Given this list of marker genes Hdac3, Cbx5, Gatad2a, Mbd3, Tet1, Nrip1, Morf4l1, Brms1l, Znhit1, Ruvbl2, Ing3, Rbbp4, Cdk2ap2, Ncor2, Hdac7, Tbl1x, Chd5, Mideas, Hdac8, Ruvbl1, Dnttip1, Setd5, Kat5 (K(lysine) acetyltransferase 5), Zfp541, Rcor1, Anp32e, Sinhcaf, Hint1, Trerf1, Kdm3b, Hdac10, Mta1, Brd8, Arid4a, Mbd2, Rere, Kdm3a, Zfp217, Hdac5, Rcor2, Phf12, Trrap, Sap30, Brms1, Arid4b, Dmap1, Rcor3, Mecom, Ncor1, Srcap, Hdac2, Suds3, Phf21a, Ep400, Mta2, Csnk2a1, Hdac6, Gatad2b, Ogt, Tbl1xr1, Ing2, Sall1, Jmjd1c (NCBI Gene Id 71364), Sap18, Hdac1, Actr6, Hdac11, Sin3b, Hdac9, Sap130, Sin3a, Hr, Chd4, Satb2, Hdac4, Ing1, Rbbp7, Mta3, Sap30l, Chd3, Cfdp1, Cdk2ap1rt, Kmt2e, Cdk2ap1, here is a description of the gene set: A protein complex that possesses histone deacetylase activity. studied in species Mus musculus Mouse Gene Set: GOCC_HISTONE_DEACETYLASE_COMPLEX